The following is a description of a gene set: The presence of developmental dysplasia of the cerebral cortex. studied in species Homo sapiens Cortical dysplasia Human Gene Set: HP_CORTICAL_DYSPLASIA, and this is the list of marker genes: ASNS, SCN1A, PRRT2, ADGRG1, ARHGAP31, POMT1, COL4A1, AKT3, FIG4, TUBB2B, SLC12A2, CNTNAP2, CUL4B, NUP133, RNU4-2, TSC2, IFNG, PTEN, PIK3CA, GABRG2, ATP6V0A1, SLC35A2, TUBB2A, NPRL3, HSD17B4, SNAP29, DYNC1H1, DDX3X, DEPDC5, SCN1B, ADGRV1, TUBB3, FGF13, NPRL2, ASPM, DLL1, SIN3A, GABRD, FGFR1, TSC1, KIF5C, SCN2A, YY1, NEDD4L, SCO2, RTTN, HCN1, STX1B, B4GAT1, TUBB, SCN9A, SIN3B, COL3A1, VPS37A, KIF2A, MTOR, COPB2